Given this list of marker genes Scn10a, Scn1b, Cacna1h, Scn5a, Scn2a, Scn11a (sodium channel, voltage-gated, type XI, alpha), Scn4b, Scn3b, Scn3a, Scn8a, Cacna1g, Scn1a, Cacna1i, Scn9a, Scn4a, Scn2b, here is a description of the gene set: A sodium channel in a cell membrane whose opening is governed by the membrane potential. Mouse Gene Set: GOCC_VOLTAGE_GATED_SODIUM_CHANNEL_COMPLEX studied in species Mus musculus